The following is a description of a gene set: Cytokines mediate cell-cell communication in the immune system and represent important therapeutic targets. A myriad of studies have highlighted their central role in immune function, yet we lack a global view of the cellular responses of each immune cell type to each cytokine. To address this gap, the authors created the Immune Dictionary, a compendium of single-cell transcriptomic profiles of more than 17 immune cell types in response to each of 86 cytokines (>1,400 cytokine-cell type combinations) in mouse lymph nodes in vivo. A cytokine-centric view of the dictionary revealed that most cytokines induce highly cell-type-specific responses. For example, the inflammatory cytokine interleukin-1β induces distinct gene programmes in almost every cell type. A cell-type-centric view of the dictionary identified more than 66 cytokine-driven cellular polarization states across immune cell types, including previously uncharacterized states such as an interleukin-18-induced polyfunctional natural killer cell state. Mouse Gene Set: CUI_T_CELL_CD8_C3A_RESPONSE_DN studied in species Mus musculus Genes negatively differentially expressed in cell type: CD8+ T cell upon treatment with cytokine: C3a in mouse lymph nodes in vivo. from publication Cui A, Huang T, Li S, Ma A, Pérez JL, Sander C, Keskin DB, Wu CJ, Fraenkel E, Hacohen N (PMID 38057668), and this is the list of marker genes: Fos, Cd69, Klf2, Hspa1b, Hspa1a, Klf6